Given this list of marker genes MAPK3 (NCBI Gene Id 5595), MAP2K1, PLAU, ITGB3 (integrin subunit beta 3), SPP1, ITGAV, CHUK, IKBKB, RELA, MMP9, MAP3K14 (NCBI Gene Id 9020), NFKB1, MAPK1, here is a description of the gene set: species: Homo sapiens Osteopontin signaling Human Gene Set: WP_OSTEOPONTIN_SIGNALING